Given this list of marker genes CXCR4, TNFRSF18, ITGA1, CTSW, GATA3, CRTAM, KRT81, DUSP2, RGS1, CD7, KLRC1, SLA2, MYL12A, CXCR3, GNLY, KLRD1, KRT86, HOPX, SH2D1B, XCL2, XIST, KLRC2, PRF1, IL2RB (NCBI Gene Id 3602), XCL1, GZMB, SOCS1, KLRC3 (killer cell lectin like receptor C3), CD69, B2M, HLA-C, ZNF683, NKG7, ID2, here is a description of the gene set: from publication Travaglini KJ, Nabhan AN, Penland L, Sinha R, Gillich A, Sit RV, Chang S, Conley SD, Mori Y, Seita J, Berry GJ, Shrager JB, Metzger RJ, Kuo CS, Neff N, Weissman IL, Quake SR, Krasnow MA (PMID 33208946) Human Gene Set: TRAVAGLINI_LUNG_NATURAL_KILLER_T_CELL studied in species Homo sapiens